The following is a description of a gene set: Reactome Pathway: SCF(Skp2)-mediated degradation of p27/p21 studied in species Mus musculus part of: Cyclin A:Cdk2-associated events at S phase entry; Cyclin E associated events during G1/S transition  electronically inferred by orthology from the curated human pathway This event has been computationally inferred from an event that has been demonstrated in another species.<p>The inference is based on the homology mapping from PANTHER. Briefly, reactions for which all involved PhysicalEntities (in input, output and catalyst) have a mapped orthologue/paralogue (for complexes at least 75% of components must have a mapping) are inferred to the other species., and this is the list of marker genes: Psmb6, Psmb7, Psmc4, Psmd6, Psma7, Cdkn1b, Psma4, Psmc3, Psmc6, Psmb4, Cdk4, Rps27a, Psma5, Cdkn1a, Psmc5, Cul1, Psmc2, Psma6, Ccnd1, Ccne2, Ccne1, Psmd12, Psmd13, Psmd1, Ccna1, Psmb5, Psma2, Ubb, Psmc1, Psma1, Psmd7, Psma3 (proteasome subunit alpha 3)